The following is a description of a gene set: studied in species Mus musculus Mouse Gene Set: chr1A2, and this is the list of marker genes: Gm6187, E330040D14Rik, Snord87, Gm18299, Sntg1, A830018L16Rik, Cpa6, Gm6195, Vcpip1, Gm15603, Snhg6, Tcf24, Vxn (vexin), 1700034P13Rik, Rrs1, 2610203C22Rik, Prex2, Gm6152, Gm22950, Gm7445, Gm28659, Gm24173, Cops5, Mcmdc2, Gm18300, Cspp1, Gm7493, 1700047N06Rik, Gm5522, Gm7560, Ppp1r42, Gm7512, Mybl1, Adhfe1, Gm24765, Gm15604, Gm6161, Sgk3, Arfgef1